Given this list of marker genes BLM, ATM, MRE11, BRCA1, FIRRM, SLX4, RAD50, EME2, DNA2, RAD51C, RMI2, EXO1, MUS81, BARD1, RAD51, WRN, PALB2 (NCBI Gene Id 79728), SPIDR (NCBI Gene Id 23514), RAD51B, RTEL1, FIGNL1, XRCC3, BRCA2, XRCC2, BRIP1, EME1, NBN, KAT5, RAD51D, RAD51AP1, TOP3A, GEN1, SLX1A, SEM1, RMI1, RBBP8, here is a description of the gene set: part of: HDR through Homologous Recombination (HRR) studied in species Homo sapiens Reactome Pathway: Resolution of D-Loop Structures Once repair synthesis has occurred, the D-loop structure may be resolved either through Holliday junction intermediates or through synthesis-dependent strand-annealing (SDSA).